The following is a description of a gene set: Cyclin dependent kinases CDK4 and CDK6 regulate crucial steps in the G1 phase of the cell cycle that commit cells to transition to the S phase and ultimately divide. Many growth signaling pathways, frequently perturbed in cancer, converge on CDK4/CDK6 activation, thus driving cellular proliferation. This makes CDK4 and CDK6 promising targets for anti-cancer therapy. So far, three CDK4/6 inhibitors, palbociclib, ribociclib and abemaciclib, have been approved for clinical use and many others are at different stages of clinical testing. CDK4/6 inhibitors mainly have a cytostatic effect on tumor cells, but can also influence immune response to tumor by targeting immune system cells in the tumor microenvironment. While intact RB1, the main target of CDK4/6 during cell cycle progression, is in general considered to be a prerequisite for the success of CDK4/6-targeted anti-cancer therapy, the status of other, less explored CDK4/6 targets can also affect the treatment outcome. For review, please refer to Asghar et al. 2015, Klein et al. 2018, Álvarez-Fernández and Malumbres 2020, Petroni et al. 2020). studied in species Homo sapiens part of: Cyclin D associated events in G1 Reactome Pathway: Drug-mediated inhibition of CDK4/CDK6 activity, and this is the list of marker genes: CCND2, CDK4, CDK6, CCND3, CCND1